Given this list of marker genes IGHMBP2, MTCO3P12, MT-TL1, RCCD1, SUMO1P3, JPX, MT-TP, WDR72, MT-TT, MT-TE, RCCD1-AS1, ZNF615, MTRFR, FBXO21, MT-ND1, here is a description of the gene set: Genes containing one or more binding sites for (ZNF136) in their promoter regions (TSS -1000,+100 bp) as identified by GTRD version 20.06 ChIP-seq harmonization. from publication Yevshin I, Sharipov R, Kolmykov S, Kondrakhin Y, Kolpakov F (PMID 30445619) species: Homo sapiens Human Gene Set: ZNF136_TARGET_GENES